The following is a description of a gene set: Binding to damaged DNA. species: Mus musculus Mouse Gene Set: GOMF_DAMAGED_DNA_BINDING, and this is the list of marker genes: Zfp950, Aunip, Polk, Ercc2, Polh, Ep300, Ddb1, Xrcc6 (NCBI Gene Id 14375), Hmces, Ercc1, Dclre1a, Ercc4, Hmgb2, Zfp1005, Parp2, Sde2, Recql4, Dclre1c, Zfp997, Neil1, Msh3, Rad23b (NCBI Gene Id 78352), Pcna, Xpc, Rpa2, Xpa, Hmgb1, Blm, Wrn, Mutyh, Ercc5, Neil2, Aptx, Gm14399, Msh6, Cry2, Zfp442, Zfp970, Nbn, Zfp1007, Msh2, Gm3604, Dclre1b, Smc6, Gm14443, Poli, Pold1, Ung, Cyren, Zfp976, H2ax, Gm32687, Trp63, Sirt6, Polb, Pot1b, Neil3, Brca1, Crebbp, Nthl1, Kdm4d, Ogg1, Trp53bp1, Rad23a, Apex1, Xrcc5, Rpa1, Trpc2, Xrcc1, Ddb2, Brme1 (break repair meiotic recombinase recruitment factor 1), Gm45871, Cul4b, Rps3, Rev1, Rbbp8, Parp1, Rpa3, Zfp433, Gm14412, Pot1a